Given this list of marker genes SLC29A1, LAPTM5, RINL, CLDN19, MMRN2, C16orf92, PLA2G4F, OPRL1, SLC12A8, FGD4, PKLR, ART1, GPR35, C1RL, RUFY4 (NCBI Gene Id 285180), MYO3B, PTPRVP, DMTN, EMILIN1, ACOT11, LRCOL1, STRA6, ZNF583, MIP, ZSCAN2, NYAP1, PRX, NR0B2, C6orf118, KCNN4, STON2, ADAMTSL1, HDC, PRICKLE3, IFI35, ANGPTL2 (NCBI Gene Id 23452), GPSM3, GGNBP1, TBC1D10C, IL17RC, ZFP57, PRRG2, CD68, TRIM21, KCNIP3, TNIP1, GPA33, TANGO2, PHYHD1, MRPS21, MASP2, TNFSF13, VWA5A, DLGAP3, SPI1, HACD4, NOTCH4 (notch receptor 4), PCOLCE, TNS2, SEPTIN1, TAPBPL, SNX10, OPRK1, CLSTN3, HTR3A, CD79A, CCDC88B, F2, SLC28A1, ECRG4, NOS3, SYTL1, EBI3, VWA3A, ROBO4, MUC1, OAS3 (NCBI Gene Id 4940), ARHGEF11, NOXO1, WARS1, HSD17B14, C1orf54, ASPG, FOLR1, HIPK4, SPON2, ZMYM2, HVCN1, TIMP4, EGFL7, ITGA2B, CYP2J2, SYNE4, PTPN6, ELOVL1, TMEM248, FAM25A, QRFP (pyroglutamylated RFamide peptide), DQX1, COX7A1, SLC5A11, TNKS1BP1, AMT, SERPINB9 (serpin family B member 9), TSPAN32, FBXW10, EXOC3L1, MYL11, GCK, NANOS3, SEMA4A, SIPA1L3, DAB2IP, GJD4, FOXR2, MADCAM1 (mucosal vascular addressin cell adhesion molecule 1), ART5, ZFAND6, CYP4F8, CYSRT1, DOC2GP, PIPOX, TREX1, MARK2, RNF151, PRR15L, SPEF2, FUT2, STYXL2, TEF, KLHDC7A, IGFALS, HEXIM2, NEU4, F5, GPR173, PDGFRB (platelet derived growth factor receptor beta), PSTPIP1, C20orf96, P2RX6, SCN2B, SUSD2, ACSBG2, SLC39A4, CNTNAP2, IFITM1, GPR20, EMP3, DAPK3, SOAT2, PODNL1, FGF1, CCDC120, PIRT, ASPDH, GLMP, GSTM1, PINLYP, CAB39, SELPLG (NCBI Gene Id 6404), GLRX, ARAP1, LST1, GULOP, CCDC121, MAB21L3, RIPPLY1, RORC, PDE4A, NLRC3, XAF1, ALDH3B1, CAPG, KISS1, UNC13D, here is a description of the gene set: Somatic cells can be reprogrammed to a pluripotent state through the ectopic expression of defined transcription factors. Understanding the mechanism and kinetics of this transformation may shed light on the nature of developmental potency and suggest strategies with improved efficiency or safety. Here we report an integrative genomic analysis of reprogramming of mouse fibroblasts and B lymphocytes. Lineage-committed cells show a complex response to the ectopic expression involving induction of genes downstream of individual reprogramming factors. Fully reprogrammed cells show gene expression and epigenetic states that are highly similar to embryonic stem cells. In contrast, stable partially reprogrammed cell lines show reactivation of a distinctive subset of stem-cell-related genes, incomplete repression of lineage-specifying transcription factors, and DNA hypermethylation at pluripotency-related loci. These observations suggest that some cells may become trapped in partially reprogrammed states owing to incomplete repression of transcription factors, and that DNA de-methylation is an inefficient step in the transition to pluripotency. We demonstrate that RNA inhibition of transcription factors can facilitate reprogramming, and that treatment with DNA methyltransferase inhibitors can improve the overall efficiency of the reprogramming process. from publication Mikkelsen TS, Hanna J, Zhang X, Ku M, Wernig M, Schorderet P, Bernstein BE, Jaenisch R, Lander ES, Meissner A (PMID 18509334) species: Mus musculus Human Gene Set: MIKKELSEN_IPS_LCP_WITH_H3K4ME3 Table 2S. Genes in MEF, MCV6, MCV8.1 and ES cells by epigenetic mark of their promoter